Given this list of marker genes ADAMTS1, THBS3, SFRP1, FKBP1A, WNT10B, TGFBR3, OVOL2, COL1A1, VEGFA, CHAD, FBN2, TEK, CAV3, SLC40A1, MMP2, ADGRG6, SRF, HEY1, FHL2, HEY2, GREM1, NKX2-5, EGLN1, MSX2, BMP10, RBP4, here is a description of the gene set: The process of creating a trabecula in an organ. A trabecula is a small, often microscopic, tissue element in the form of a small beam, strut or rod, which generally has a mechanical function. Trabecula are usually but not necessarily, composed of dense collagenous tissue. studied in species Homo sapiens Human Gene Set: GOBP_TRABECULA_FORMATION